The following is a description of a gene set: species: Homo sapiens Subcortical white matter calcifications Human Gene Set: HP_SUBCORTICAL_WHITE_MATTER_CALCIFICATIONS, and this is the list of marker genes: KARS1, SNORD118, ERCC1, NAA60, ERCC8, ERCC6